Given this list of marker genes SLC7A1, SLC25A15, SLC7A2, SLC25A2, SLC7A3, here is a description of the gene set: studied in species Homo sapiens Human Gene Set: GOMF_L_ORNITHINE_TRANSMEMBRANE_TRANSPORTER_ACTIVITY Enables the transfer of L-ornithine from one side of a membrane to the other. L-ornithine is 2,5-diaminopentanoic acid.